The following is a description of a gene set: Persistent CMV viremia species: Homo sapiens Lasting (uncontrolled) presence of cytomegalovirus in the blood circulation. Human Gene Set: HP_PERSISTENT_CMV_VIREMIA, and this is the list of marker genes: LAT, TPP2, REL, PIK3R1, MAGT1, CD28, IL2RB